Given this list of marker genes Pcid2, Bad, Xbp1, Card11, Ankle1, Mir150, Spi1, Pnp, Slamf8, Hmgb3, Id2, Stat5b, Ptpn6, Atp11c, Lilrb4a, Zfp36l2, Ddrgk1, Ppp2r3c, Cd24a, Il7 (NCBI Gene Id 319295), Ikzf3, Il4i1, Cyld, Stat5a, Mmp14, Zfp36l1, Nfam1, Bcl6 (NCBI Gene Id 12053), Tlr9, Inpp5d, Syk, Nckap1l, Il2, Sfrp1, Flt3, Il21, Fas, Cd27, Il2rg (interleukin 2 receptor, gamma chain), Il10, here is a description of the gene set: Mouse Gene Set: GOBP_REGULATION_OF_B_CELL_DIFFERENTIATION studied in species Mus musculus Any process that modulates the frequency, rate or extent of B cell differentiation.